Given this list of marker genes Tacr3, Kcnq1, Adra1b, Adm2, Adm, Apln, Edn1, Adrb1, Atp5pf, Edn3, Nmu, Pde4d, Tpm1, Ada (NCBI Gene Id 11486), Rgs4, Hrc, Nppa, Uts2, Scn3b, Ryr2, Adra1a, Scn5a, Slc1a1, Hey2, Avpr1a, Chrna7, Edn2, Trpm4, Sirt1, Crhr2, Gch1, Ptpn1, here is a description of the gene set: Mouse Gene Set: GOBP_POSITIVE_REGULATION_OF_HEART_RATE species: Mus musculus Any process that activates or increases the frequency or rate of heart contraction.